Given this list of marker genes Bfsp2, Crygb, Tbc1d20, Frs2, Epha2, Fgfr2, Cryaa, Fgfr3, Prox1, Abi2, Smarca4, Bfsp1, Vim, Tmod1 (NCBI Gene Id 21916), Atf4, here is a description of the gene set: The process whose specific outcome is the progression of a lens fiber cell over time, from its formation to the mature structure. Cell development does not include the steps involved in committing a cell to a lens fiber cell fate. A lens fiber cell is any of the elongated, tightly packed cells that make up the bulk of the mature lens in a camera-type eye. Mouse Gene Set: GOBP_LENS_FIBER_CELL_DEVELOPMENT species: Mus musculus